Given this list of marker genes Syt1, Rims1, Unc13b, Snap25, Ppfia3, Tspoap1, Ppfia4, Stx1a, Slc22a2, Cplx1, Ppfia1, Vamp2, Slc22a1, Maoa, Stxbp1, Slc18a2, Ppfia2, Rab3a, here is a description of the gene set: Mouse Gene Set: REACTOME_NOREPINEPHRINE_NEUROTRANSMITTER_RELEASE_CYCLE Norepinephrine Neurotransmitter Release Cycle species: Mus musculus